Given this list of marker genes PRKAR1A, RARA, STAT5B, F10, F13A1, IRF2BP2, F2, KIF23, TBL1XR1, RACGAP1, NUMA1, F5, NABP1 (NCBI Gene Id 64859), FIP1L1, BCOR, STAT3, PML, NPM1, F13B (coagulation factor XIII B chain), ZBTB16, F8, here is a description of the gene set: Recurrent or excessive bleeding from the mouth. Oral cavity bleeding Human Gene Set: HP_ORAL_CAVITY_BLEEDING species: Homo sapiens